The following is a description of a gene set: Regulatory T (Treg) cells that express the FoxP3 transcription factor are essential for lymphoid homeostasis and immune tolerance to self. Other non-immunological functions of Treg cells, such as controlling metabolic function in adipose tissue, are also emerging. Treg cells originate primarily in the thymus, but can also be elicited from conventional T cells by in vivo exposure to low-dose antigen or homeostatic expansion, or by activation in the presence of TGFβ in vitro. Treg cells are characterized by a distinct transcriptional signature controlled in part, but not solely, by FoxP3. For a better perspective on transcriptional control in Treg cells, we compared gene expression profiles of a broad panel of Treg cells from various origins or anatomical locations. Treg cells generated by different means form different sub-phenotypes identifiable by particular combinations of transcripts, none of which fully encompass the entire Treg signature. Molecules involved in Treg effector function, chemokine receptors, and the transcription factors that control them are differentially represented in these subphenotypes. Treg cells from the gut proved dissimilar to cells elicited by exposure to TGFβ, but instead they resembled a CD103+Klrg1+ subphenotype preferentially generated in response to lymphopenia. Human Gene Set: GSE20366_EX_VIVO_VS_HOMEOSTATIC_CONVERSION_TREG_DN Genes down-regulated in comparison of TregLP versus Homeo Convert (see Table 1S in the paper for details). species: Homo sapiens from publication Feuerer M, Hill JA, Kretschmer K, von Boehmer H, Mathis D, Benoist C (PMID 20231436), and this is the list of marker genes: ABCA6, MGAT4A, NALCN (NCBI Gene Id 93074), ERI1, DPP4, HSD17B7, HMGB2, SH2D4A, SGO1, ALOX5AP, GPRIN3, CALR, BIRC5, TMPRSS4, RIPOR2, CCNA2, CENPP, CENPE, TAMALIN, TMEM39B, PCLAF (NCBI Gene Id 9768), UCK2, CDHR3 (NCBI Gene Id 222256), NR0B2, ZRANB3, IGLL1, ACAT1, HDHD3, LRR1, EML6, FAM114A1, BCAT1, TXNDC12, TYMS, HOXC10, RPL38, NICN1, UGT2B4, IRAK1BP1, SPC24, NCAPG2, ANKRD34A, CAMSAP2, NDRG1, C19orf38, TLCD2, CNDP2, ITPKA, CENPF, BPNT1, CCNB2, KPNA2, DDIAS, HAX1, NEK1, CACNA2D2, C8G, ENPP2, CENPW, EPSTI1, CCDC34, PARPBP, CDC25C, ECT2, SMYD2, STT3B, EHF, ZNF239, PLSCR3, SYCE2, INCENP, DGLUCY (NCBI Gene Id 80017), YWHAZ, GCNT2, ACTR3B, ADGRL1, MKI67, KERA, HAVCR1, RARG, SANBR, MAP7D1, MYB (MYB proto-oncogene, transcription factor), SYT11, TMCO5A (transmembrane and coiled-coil domains 5A), CAPRIN1, IER3, VWCE, DNA2, PRSS16, AURKB, TNS1, FUNDC2, EEF2K, TMEM178A, IMPDH2, TTC5, TUSC1, SMARCD2, CRIM1, NIBAN2, ATP5MF, FXYD1, DYNLRB2, STRADB, AVEN, CRIPTO, MELK, MIS18BP1, TPM3, MS4A1, ALAD, NME4, SPICE1, KIF22, LEF1, NUSAP1, BEX1, ALDH1L2, NDUFC1, ATP4A, CPOX, GPR18, SATB1, VGLL3, UBL4B, TRIP13, HINT1, ZNF606, MAPK3, COMTD1, C6orf141 (chromosome 6 open reading frame 141), VCL, ARID3B, IL1RAPL1, NINJ2, RAPGEF3, EID1, SBK1, METTL9, GABRA2, RASSF2, PIK3R6, CYP27B1 (cytochrome P450 family 27 subfamily B member 1), SLAMF6, SPATA6, PSME3, ZBTB18, NOD1, TTBK2, ERC1, UBE2C, IL6R, CA7, FAM171B, GNAL, SLC25A4, IFI30, CALB1, PPL, GCAT, CREBL2, ATP5ME, LRRC3B, GPSM2, PLCD1, PLP2, PDLIM1, ASF1B, MYADM, STMN1, DTL, CERS6, CDCA2, CHEK1, RND3, SMC2, RANBP1, OTOR, KIF4A, B3GNT5, WDR83OS, SOCS2, F2RL3, MTHFD2, IGFBP4, SMC5, BUB1, GADD45G, H2AZ1, KCNK6, WAS, ASPM, E2F2, PBK, SGO2, DYNLT2B, PAX7, CDC20, DPY19L1